Given this list of marker genes RBM15, METTL9, CMTR1, FAM86C2P, METTL15P1, RAB6A, ETFBKMT, SNRPD1, EEF1AKMT2, PEMT, PRDM7, BHMT2, MRM1 (mitochondrial rRNA methyltransferase 1), TRMT11, LCMT2, PRMT8 (NCBI Gene Id 56341), DNMT3A, SNRPG, PRDM6, WDR4 (WD repeat domain 4), RAMACL, MTAP, AS3MT, ANTKMT, SMYD2, EZH1, BHMT, TYW3, DOT1L, HNMT, METTL1, KMT2D, SETD5, LARP7, NOP2, PRDM15, CSKMT, SNRPD2, HENMT1 (NCBI Gene Id 113802), SETD1A, ASH1L, NSD1, HEMK1, SPOUT1, SLC25A26, KMT2A, PRMT5, COQ3, SNRPD3, NSD2, METTL22, ECE2, GNMT (NCBI Gene Id 27232), THUMPD3, PRDM11, LCMT1, EEF2KMT, BUD23, MEPCE, FAM86B2, NSUN3, FAM86B1, COQ5, PNMT, TRMO, THADA, SETD4, SETMAR, COMT, EMG1, PRDM10, HSD17B10, METTL3, MGMT, NNMT, EEF1AKMT1, PRMT9, SETD2, FBL, N6AMT1, RBM15B, SETD3, PRDM8, VCPKMT, SNRPE, DNMT3L, ARMT1, MTR, METTL13 (methyltransferase 13, eEF1A N-terminus and K55), CMTR2, INMT, NSUN6, NSUN5, PRDM12, FAM86C1P, NSUN4, TRMT1L, TMT1B, NTMT1, TRMT5, EEF1AKMT3, METTL2B, DIMT1, TRMT61A, DNMT3B, TRMT13, PRDM1, EZH2, SETD1B, SAMTOR, PRDM14, TRMT2A, PRMT2, SMYD4, FDXACB1, TRMT9B, TRMT112, NSUN2, METTL21C, TRMT2B, TRMT10B, METTL15, METTL8, FBLL1, KMT5A, CYP1A2, METTL21EP, TGS1, METTL5, KMT2C, PRMT7, KMT5C, CAMKMT, FAM98A, AKT1, TRMT10C (tRNA methyltransferase 10C, mitochondrial RNase P subunit), NDUFAF5, PRMT3, FTSJ3, ASMT, PCMT1, GSPT1, METTL6, TRMT12, CARNMT1, COMTD1, METTL16, KMT2B, SUV39H2, SMYD5, SETD6, TPMT, THUMPD2, METTL25B, TARBP1, NSUN5P2, FAM98B, TRMT44, NTMT2, PRDM9, TRMT10A, PRDM4, TFB1M, TRMT1, WDR6, DALRD3, SETDB2, TRMT6, NSUN7, EEF1AKMT4, TYMS, NSD3, RRP8, CARM1, PRMT1, MECOM, PRDM13, PRDM16, METTL4, BCDIN3D, SMYD3, ATPSCKMT, ALKBH8, TRDMT1, MRM3, MTO1, PRDM5 (NCBI Gene Id 11107), EHMT2, SNRPF, METTL2A (NCBI Gene Id 339175), KMT5B, TFB2M, SETD7, PRDM2, SETD9, TRMT61B, PCIF1, EEF1AKMT4-ECE2, NDUFAF7, PRMT6, MRM2, SMYD1 (NCBI Gene Id 150573), METTL21A, GAMT, METTL18, TMT1A, ZCCHC4, METTL25, DPH5, RNMT, METTL23 (NCBI Gene Id 124512), ETF1, SUV39H1 (NCBI Gene Id 6839), SNRPB (NCBI Gene Id 6628), FTSJ1, DNMT1, ASMTL, SETDB1, EHMT1, GTPBP3, ICMT, METTL14, RAMAC, NSUN5P1, METTL24, here is a description of the gene set: Human Gene Set: GOBP_METHYLATION The process in which a methyl group is covalently attached to a molecule. studied in species Homo sapiens